Given this list of marker genes CATSPER1, DAZ2, LHCGR, SEPTIN12, NR5A1, CFAP47, ARMC12, CFAP65, NR0B1, FKBP6, DAZ4, POR, DNHD1, LRRC23, NR3C1, IFT74, CATSPER2, POC1A, PDE11A, ARMC2, RPL10L, DNAH10, CCDC34, USP9Y, PMFBP1, TDRD9, ANTXR1 (NCBI Gene Id 84168), DRC1, MSH4, ALMS1, TSPY1, BRWD1, KCNU1, KLHL10, CFTR, PRKAR1A, FBXO43, ADGRG2, CATIP, DNAH17, CNBP, DZIP1, RBMY1A1, CCDC146, DAZ1, PDHA2, TEKT3, CEP19, CYLC1, STK33, CFAP91, FSHB, SYCP2, M1AP (meiosis 1 associated protein), CFAP61, DAZ3, TEX15, CCIN, BLM, CFAP70, DDX3Y, MEIOB, STRC, SUN5, here is a description of the gene set: species: Homo sapiens Reduced count of spermatozoa in the semen, defined as a sperm count below 20 million per milliliter semen. Oligozoospermia Human Gene Set: HP_OLIGOZOOSPERMIA